Given this list of marker genes AEBP1, FUZ, TBXT (NCBI Gene Id 6862), VANGL1, VANGL2, CCL2, here is a description of the gene set: studied in species Homo sapiens Human Gene Set: HP_ABNORMALITY_OF_SPINAL_FACET_JOINT An anomaly of the small joints located between and behind adjacent vertebrae. Abnormality of spinal facet joint